Given this list of marker genes DCT, TYR, OPN3, SLC45A2, RAPGEF2, SLC24A5, CYP1A2, GIPC1, ZEB2, WNT5A, PMEL, MFSD12, TRPC1 (NCBI Gene Id 7220), APPL1, CITED1, CDH3, OCA2, DDT, TYRP1, RAB38, SLC7A11, ATP7A, CTNS, ASIP, BDH2, MC1R, here is a description of the gene set: Human Gene Set: GOBP_SECONDARY_METABOLITE_BIOSYNTHETIC_PROCESS species: Homo sapiens The chemical reactions and pathways resulting in the formation of secondary metabolites, the compounds that are not necessarily required for growth and maintenance of cells, and are often unique to a taxon.